The following is a description of a gene set: electronically inferred by orthology from the curated human pathway part of: GABA B receptor activation This event has been computationally inferred from an event that has been demonstrated in another species.<p>The inference is based on the homology mapping from PANTHER. Briefly, reactions for which all involved PhysicalEntities (in input, output and catalyst) have a mapped orthologue/paralogue (for complexes at least 75% of components must have a mapping) are inferred to the other species. species: Mus musculus Reactome Pathway: Activation of GABAB receptors, and this is the list of marker genes: Gngt1, Gnb5, Kcnj10, Adcy5, Gng11, Kcnj5, Gnai1, Kcnj2, Kcnj12, Kcnj3, Adcy8, Adcy7, Gng5, Gnb3, Gnat3, Gng8, Gng4, Gngt2, Gabbr1, Gng3 (guanine nucleotide binding protein (G protein), gamma 3), Gng10 (guanine nucleotide binding protein (G protein), gamma 10, NCBI Gene Id 14700), Gnb2, Gng7 (NCBI Gene Id 14708)